The following is a description of a gene set: Genes predicted to be targets of miRBase v22 microRNA mmu_miR_668_5p in miRDB v6.0 with MirTarget v4 prediction scores > 80 (high confidence targets). species: Mus musculus from publication Chen Y, Wang X (PMID 31504780) Mouse Gene Set: MIR_668_5P, and this is the list of marker genes: Myrf, Terb2, Cntn1, Rab11a (NCBI Gene Id 53869), Vps29, Qser1, Arid4b, Neurl4, Kcna2, Farp2, Gnai1, Cbll1 (NCBI Gene Id 104836), Mylk, Washc4, Pax9, Mstn, Dera, Kdm1b, Ube4a, Utrn, Fancc, Myb, Lonrf1, Sap18, Ssxb10, Skida1, Raph1, Kcnj6, Ssr1, Srgap1, Dnajc3, Fam120c, Eif4h, Caprin2, Saxo2 (NCBI Gene Id 67368), Wapl, Itgb4, Tpd52, Zfp521, Mageb16, Abcc2, Dimt1, Spata6l, Camk4, Etfrf1, Ms4a5, Snx5, Trio, Nipa1, Dmxl1, Nek7, Katnbl1, Crem, Cadps2, Pcdh7, Nampt, Gja6, Cltb, Cald1, Cnot6l, Gpm6b, Thsd7a, Znrf3, Tmc7, Arhgap29, Zdhhc13, Hyal4, Tent4b, Fzd6, Atp1b1, Zbtb41, Mtpn, Trappc8, Sp3